The following is a description of a gene set: Human Gene Set: GOBP_REGULATION_OF_ANDROGEN_RECEPTOR_SIGNALING_PATHWAY species: Homo sapiens Any process that modulates the rate, frequency, or extent of the androgen receptor signaling pathway., and this is the list of marker genes: KDM4C, PHB1, RNF14, TCF21, PIAS2, TRIM68, IGF1, FOXH1, PKN1, PRMT2, NCOR1, EP300, KDM5D (NCBI Gene Id 9773), SAFB, HEYL, RNF6, SMARCA4, HDAC6, DDX5 (NCBI Gene Id 1655), NCOR2, HDAC1, FOXP1, PARK7 (Parkinsonism associated deglycase), SAFB2, SHQ1, ZBTB7A, NODAL, DAB2, SIRT1, SFRP1, KDM1A, TAF1, TCF7L2, USP26